The following is a description of a gene set: The binding of a cell to the extracellular matrix via adhesion molecules. Mouse Gene Set: GOBP_CELL_MATRIX_ADHESION species: Mus musculus, and this is the list of marker genes: Fermt2, Nexmif, Adamts9, Mmp14, Ccl21a, Csf1, Trem1, Itga1, Utrn, Disc1, Itga6, Actn1, Bcl6, Col16a1, Myoc, Itga8, Cfl1, Fga, Ldb1, Vwa2, Itga5, Grem1, Bcan, Agt, Pecam1, Thy1, Itgb2, Srf, Itgam, Cd63, Coro2b, Bcl2, Bcl2l11, Ppm1f, Dusp3, Pdpk1 (3-phosphoinositide dependent protein kinase 1), L1cam, Sorbs1 (NCBI Gene Id 75688), Itgb8, Tecta, Ptpn11, Ilk, Ptprk, Itgb6, Zfp469, Vtn, Epha3, Bcam, Nrp1, Tmem8b, Itgb4, Tesk2, Dicer1, Actn2, Fermt1, Plau, Pxn, Actn3, Ninj1, Mia, Nid1, Otoa, Ccl21d, Taok2, S100a10, Actg1, Postn, Fam107a (NCBI Gene Id 268709), Angptl3, Pip5k1a, Coro1c, Peak1, Lrp1, Itga4, Cd3e (NCBI Gene Id 12501), Ccl21f, Ccl25, Itgbl1, Myf5 (NCBI Gene Id 320915), Adam8, Acvrl1, Hpse, Prkcz, Dlc1, Pik3r1, Lypd3, Gp5, Plpp3, Dmd, Adamts12, Rhod, Fgg, Sned1, Ccl21e, Cntn2, Dusp22, Pcsk5, Itgb5, Pten, Itga3, Hoxd3, Ccl21b, Rhpn1, Itgav, Adam9, Ston1, Trpm7, Zyx, Nid2, Nf1, Src, Hrg, Itgad, Enpp2 (ectonucleotide pyrophosphatase/phosphodiesterase 2), Bcr, Gsk3b, Apod, Map4k4, Sirpa, Jup, Cdk5, Mslnl, Cdh13, Rock1, Thbs1, Ptk2b, Sdc4, Emp2, Itga9, Hoxa7, Madcam1, Itgb7, Itgae, Ajap1, Cd34, Onecut1, Itgb3, Sec1, Thsd1, Gfus, Tsc1, Tiam1, Itga10 (integrin, alpha 10), Dag1, Emilin1, Smad3, Plet1, Fn1, Dmtn, Limch1, Kdr, Rras, Ddr1, Strc, Rcc2, Cdh11, Ccn2, Rin2, Abl1, Tek, Itga7, Cttn, Cd96, Efemp2, Col3a1, Epdr1, Efna5, Cripto, Col13a1, Jag1, Clasp1, Epha1, Msln, Fut1, Poldip2, Mmp12, Iqgap1 (IQ motif containing GTPase activating protein 1), Itgb1, Gpm6b, Cib1, Ccl28, Itgb1bp1, Cask, Vcam1, Itga2, Tnn, Adam15, Muc4, Rasa1, Arhgap6, Itgal, Ptprj, Fmn1, Cdk6, Itga11, Cdkn2a, Svep1, Pkhd1, Cd36, Dapk3, Anxa2, Tnxb, Wnt4, Wdpcp, Eda, Acer2, Ptpra, Vcl, Camsap3, Rhoa, Serpine1, Frem1, Itgax, Col5a3, Bst1 (NCBI Gene Id 269647), Npnt, Lims1, Rac1, Epb41l5, Slk, Mkln1, Ajuba, Sema3e (sema domain, immunoglobulin domain (Ig), short basic domain, secreted, (semaphorin) 3E), Itga2b, Ptk2, Macf1, Skap1, Ctnnb1, Fgb, Whamm, Pik3cb, Phldb2, Jam3, Myh9, Fermt3, Clasp2, Itgb2l, Onecut2, Mink1, Vegfa, Plekha2